The following is a description of a gene set: species: Homo sapiens Human Gene Set: GOBP_POSITIVE_REGULATION_OF_ACUTE_INFLAMMATORY_RESPONSE Any process that activates or increases the frequency, rate, or extent of an acute inflammatory response., and this is the list of marker genes: BTK, FFAR3, FCER1G, C3, FFAR2, CCR7, TNF, MIR92A1, HLA-E, PARK7, OSMR, TNFSF11, TNFRSF11A, ZP3, CREB3L3, PTGER3, IL1B, PIK3CG, IL6, FCGR1A, IL6ST, PTGS2, TAC1, ADAM8 (ADAM metallopeptidase domain 8), NPY5R (NCBI Gene Id 4889), C2CD4B, C2CD4A, OSM